Given this list of marker genes Slitrk1, Slitrk6, Ptprs, Ppfia3 (protein tyrosine phosphatase, receptor type, f polypeptide (PTPRF), interacting protein (liprin), alpha 3), Slitrk4, Il1rapl2, Ppfibp1, Ppfibp2, Ppfia2, Lrrc4b, Slitrk2, Ptprf, Slitrk5, Slitrk3, here is a description of the gene set: studied in species Mus musculus Reactome Pathway: Receptor-type tyrosine-protein phosphatases This event has been computationally inferred from an event that has been demonstrated in another species.<p>The inference is based on the homology mapping from PANTHER. Briefly, reactions for which all involved PhysicalEntities (in input, output and catalyst) have a mapped orthologue/paralogue (for complexes at least 75% of components must have a mapping) are inferred to the other species. electronically inferred by orthology from the curated human pathway part of: Protein-protein interactions at synapses